Given this list of marker genes Fcgr2b, H2-D1, Gngt2, B2m, Klf2, Jund, Plac8, H2-K1, Arhgef18, Eef2, here is a description of the gene set: Genes negatively differentially expressed in cell type: Monocyte upon treatment with cytokine: M-CSF in mouse lymph nodes in vivo. Cytokines mediate cell-cell communication in the immune system and represent important therapeutic targets. A myriad of studies have highlighted their central role in immune function, yet we lack a global view of the cellular responses of each immune cell type to each cytokine. To address this gap, the authors created the Immune Dictionary, a compendium of single-cell transcriptomic profiles of more than 17 immune cell types in response to each of 86 cytokines (>1,400 cytokine-cell type combinations) in mouse lymph nodes in vivo. A cytokine-centric view of the dictionary revealed that most cytokines induce highly cell-type-specific responses. For example, the inflammatory cytokine interleukin-1β induces distinct gene programmes in almost every cell type. A cell-type-centric view of the dictionary identified more than 66 cytokine-driven cellular polarization states across immune cell types, including previously uncharacterized states such as an interleukin-18-induced polyfunctional natural killer cell state. from publication Cui A, Huang T, Li S, Ma A, Pérez JL, Sander C, Keskin DB, Wu CJ, Fraenkel E, Hacohen N (PMID 38057668) Mouse Gene Set: CUI_MONOCYTE_M_CSF_RESPONSE_DN species: Mus musculus